Given this list of marker genes SLC9A4, NDUFA10, ATP5F1C, ATP5MC2, NDUFC1, NDUFS2, NDUFB9, COX7A2L, NDUFB4, MT-ND2, SLC16A1, MT-CO1, ATP5PO, SLC9C1, SLC18A3, UQCRH, ATP6V1B2 (ATPase H+ transporting V1 subunit B2), ATP4B, ATP1B1, NDUFS6, ATP1A1, ATP6V1C2, SLC15A3, SLC9B1, SLC36A3, NDUFV1, SLC25A12, SLC25A22, SLC32A1, MT-ATP8, ATP6V1A, SLC17A5, COX4I1, OTOP3, NDUFS7, UQCR10, ATP5PD, ATP6V1G1, UCP2, SLC2A9, SLC36A1, GHITM, UCP1, FXYD2, SLC25A4, ATP5MG, SLC4A10, CLCN7 (chloride voltage-gated channel 7), TMEM175, ASIC5, NDUFS3, SLC36A2, SLC25A18, SLC9A1, SLC25A14, SLC46A1, SLC9C2, ATP5MGL, ATP5F1D, STING1, PPIF, SLC15A2, NDUFA4, NDUFA1, ATP6V1E2, ATP6V0B, SLC25A3, UCP3, OTOP2, SLC17A7, ATP5MC3, SLC17A6, ATP6V0A2, NDUFA7, NDUFV3, PHB2, MT-ND4 (NCBI Gene Id 4538), NDUFS8, SLC9A2, MTCO2P12, MT-ATP6, SLC25A27, DMAC2L, NDUFS4, NDUFB8, ATP6V1B1, TCIRG1, NDUFB5, SLC47A1, NDUFS5, ATP5PF (ATP synthase peripheral stalk subunit F6), HVCN1, SLC9A9, ATP6V0A1, ATP5F1E, ATP5ME, NDUFB10, ATP5F1EP2, COX6B1, SLC15A4 (NCBI Gene Id 121260), SLC9B1P1, TMCO3 (NCBI Gene Id 55002), MT-ND1, SLC9A8, SLC25A5, ATP6V0E1, NDUFA9 (NCBI Gene Id 4721), ATP1A3, IL13, SLC4A11, ATP1A4, SLC9A6, OTOP1, ATP6V0D1, ATP5MC1, SLC9A7, COX5B, MT-ND4L (NCBI Gene Id 4539), SLC18A1, SLC11A2, ATP6V0E2, CLCN3, ATP6V1F, COX7B, ATP6V0A4, COX17, ATP5F1B, COX8A, NDUFS1, NDUFA5, CYC1, ATP12A, SLC25A13, UQCRFS1, NNT, LETM1, SLC15A1, SLC9A5 (solute carrier family 9 member A5), ATP6AP2, MT-ND5, ATP6V1D, MT-CO2, ATP5F1A, RNASEK, NDUFB6, NDUFB1 (NADH:ubiquinone oxidoreductase subunit B1), ATP6V1G3, NDUFV2, MT-ND6, SURF1, SLC18A2, SLC18B1, ATP6V1G2, SLC11A1, ATP1A2, NDUFA8, ATP5MF, UQCRC1, SLC9B2, NDUFA3, MT-CO3 (NCBI Gene Id 4514), SLC47A2, NDUFA6 (NADH:ubiquinone oxidoreductase subunit A6), MT-ND3 (NCBI Gene Id 4537), ATP4A, ATP6V0C, ATP6V1H, NDUFB3, SPHK2, CTNS, NDUFC2, ATP6V1C1, COX7A1, NDUFB7, ATP5PB, UQCRFS1P1, ATP6V1E1, NDUFA12, NDUFB2, MT-CYB, ATP6V0D2, SLC9A3, NOX5, ATP6AP1, SLC2A10, NDUFA2, COX5A, here is a description of the gene set: Human Gene Set: GOBP_PROTON_TRANSMEMBRANE_TRANSPORT The directed movement of a proton across a membrane. studied in species Homo sapiens